Given this list of marker genes VWF, APBB1IP, PDPK1, GRB2, SRC, ITGA2B, THPO, RAP1A, FN1, SYK (NCBI Gene Id 6850), CRK, RAP1B, RAPGEF3, BCAR1, ADRA2C, COL1A2, ADRA2B, FGB, GP1BA, GP1BB, TLN1, GP5, PTK2, CSK, FGG, AKT1, ADRA2A, FGA, GP9, SOS1, F2, PTPN1, SHC1, RASGRP2, RASGRP1, RAPGEF4, MPL, ITGB3, COL1A1, here is a description of the gene set: Reactome Pathway: Platelet Aggregation (Plug Formation) part of: Platelet activation, signaling and aggregation studied in species Homo sapiens The tethering of platelets to the site of vascular injury is the first step in the formation of a platelet thrombus. Firm adhesion of these tethered platelets, as well as the additional recruitment of others onto their surface leads to the formation of large platelet aggregates. The formation of a thrombus is strictly dependent on the formation of interplatelet bonds.